Given this list of marker genes INHBB, COMT, EVI2A, CALML5, SFRP4, PCK1, CCL7, COL18A1, NFIL3, DBP, S100A9, AREG, SMS, IL1R2, LSP1, CCL23, NAT8, PENK (proenkephalin), VEGFD, RNASE3, IFI16, CITED1, SLC6A6, ANGPTL2, MYCL, THBS2, TWIST1, CTSB, APBB1IP, KRT10, NPR3, TNF, PDGFRA, VPREB3, PROM1, MSR1, FOXA1, CPXM1, PI4KA, CCL8, HAL, FCRLA, TDRP, CYP4V2, IGHV4-28, EPS15, SLC30A1, EPS8, PTN, RSPH3, ELOVL6, PRRX2 (paired related homeobox 2), KRTAP6-1, LIMD2, FCGR2B (NCBI Gene Id 2213), CFH, APOD, REG3A (NCBI Gene Id 5068), NPY6R, PTEN, KLF4, CXCL12 (NCBI Gene Id 6387), MARCO, RECK, HSD11B1, AOX1, IDI1, here is a description of the gene set: Genes up-regulated in pubertal mammary glands compared to mammary glands from other developmental stages. Human Gene Set: HOWLIN_PUBERTAL_MAMMARY_GLAND from publication Howlin J, McBryan J, Napoletano S, Lambe T, McArdle E, Shioda T, Martin F (PMID 16278680) species: Mus musculus Expression microarray analysis identified CITED1 among a group of genes specifically upregulated in the pubertal mouse mammary gland. At puberty, CITED1 localizes to the luminal epithelial cell population of the mammary ducts and the body cells of the terminal end buds. Generation of CITED1 gene knockout mice showed that homozygous null mutants exhibit retarded mammary ductal growth at puberty and, in addition, dilated ductal structures with a lack of spatial restriction of the subtending branches. Analysis of CITED1 homozygous null and heterozygous null mammary gland gene expression using microarrays suggested that the mammary-specific phenotype seen in the homozygous null females is due to a disturbance in the transcription of a number of key mediators of pubertal ductal morphogenesis. These include estrogen and TGFbeta responsive genes, such as the EGFR/ErbB2 ligand, amphiregulin, whose transcription we suggest is directly or indirectly regulated by CITED1.